Given this list of marker genes SIX2, TGFBR1, KPNA1, NPAT, TTC39B, ZNF124, ZNF514, CCNDBP1, IPMK, LIN28B, CRIM1, BCLAF1, PSG5, APOO, HYCC2, ZIC2, GIGYF1, TESMIN, AIRIM, DDX3Y, TMEM131, LMO1, LIN28A, GUCY1A2, TBPL1, ZNF426, LOX, GOLGA8A, PHACTR4, RIMKLB, GLCCI1, CD69, TREML4, RIOX2, UBE2D3, SMAP1, SS18L1, PRLR, CPEB4, DUSP6, ACVR2A, ADAMTS18, TNFSF4, KANK1, ZNF704, CTDSPL, EXD1, SLC2A3, OOSP2, OTOGL, PEAK1, DYNC1LI2, PI4K2B, DEK, PAK5, TCFL5, APBA1, PARP11, CDC40, STARD4, LGALSL, AGO4, PAX5, ZBTB43, NWD2, FBXO34 (F-box protein 34), PHC3, CPD, HEY2, ZDHHC17, PCDHA9, NAAA, GOLGA8N, FNDC3A, ZNF37A, SAMHD1, RFTN2, MYCBP2, ATP2B2, PPP5D1P (PPP5 tetratricopeptide repeat domain containing 1, pseudogene), CAMTA2, LMBRD2, CDON, KCNQ5, CARM1, GSKIP, CLUH, ZNF440, RPS6KB1, CEP83, RBM47, SPRY4, ZNF479, ITGA3, ZNF268, FBXO33, KLHL2, SYNPR, SCHIP1, CAMSAP2, CDC5L, GTSE1, TOGARAM1, AKIRIN2, TRDMT1, YOD1, PLCL2, ARHGEF7, CCNK, TNIK, ETFBKMT, GOLGA1, ACSL4, ZNF584, ANO1, MAP3K3, NR2C2, ARMH4, TIMP3, IL1A, TMF1, SYT16 (synaptotagmin 16), POC1B-GALNT4, SENP2, XPO7, SELENOT, AVL9, SORD, ENDOD1, NR4A3, GALNT4, MAN2A1, LRBA, ADARB1, FUT9, ZBTB4, TNFAIP1, YTHDC2 (NCBI Gene Id 64848), NUCKS1, MAB21L3, NPEPPS, PCDHA1, AASDHPPT, OTUD4, ENTPD6, CNOT2, BACH2, PITPNB, CDYL (chromodomain Y like), ADGRB3, PSG11, P3R3URF-PIK3R3, PAX9, MIDEAS, KIF3B, CNKSR2 (connector enhancer of kinase suppressor of Ras 2), BRWD1, SEC24C, PCDHA3, GLS, PSG3, FAM135A, LPCAT2, PHLDA1, PRTG, ZNF266, GPSM1, BRAP, DCBLD2, PRKCD, CNTN4, DEPTOR, ZDHHC3, RNF34, TRAK1, GOLGA6L9, ZNF780B, NEK7, DCAF12L1, AGFG1, RAB3IP, ZNF140, UBP1, CPOX, SPP1, ZNF544, SLC4A8, MUC22, PROSER1 (NCBI Gene Id 80209), ZNF655, C2CD5, CDKN3, DARS1, TRIM2, CEP97, TMEM123, ZNF563, QSER1, BEND3, HSP90B1, UBE3C, CNKSR3, SLC22A15, MED26, NAALADL2, FHAD1, SETX, GOT2, ZFP82, DNAJC3, ECT2L, ITGB8, IGDCC3, SIN3B, CHIC1, TBC1D14, RECK, RAB30, KATNBL1, AP1AR, PURB, PHF3, NUS1, LATS1, MEGF9, MBNL2, MAP7D2, GFPT1, FHIP1A, MTF2, ZNF844, FHIP1B, KDM5A, MB21D2, G3BP2, LAMA1, ETS1 (NCBI Gene Id 2113), ACVR2B, GRB10, GHITM (NCBI Gene Id 27069), ZNF302, CD302, NIPBL, ZFP36L2, EPC2, DCLK1, GPD1L, HOXA11, TMLHE, ZFAND4, PTGR3, NLK, MYO1E, SLC16A7, IGF2BP2, IKZF5, SEC24A, KCNH1, RASSF1, FOXP1, PIK3R3, ADO, PCSK1, PALM2AKAP2, CNTNAP3B, ATP2B3, TAFA2, HIC2, NOVA1, FSBP, TMEM87B, CDH8, RALA, ZNF814, TBC1D1, FAM3C, ZEB2, DCN, WDR82, CALCR, KRBOX4, OSBPL3, KLHL42, LCTL, ZNF699, ZNF800, ANKRD13C, RAB3C, SLITRK1, UNC80, FKBP1A (FKBP prolyl isomerase 1A), CAPS2, BLOC1S6, ZNRF2, CARF, BCL2L11, CBX7, CBLL1, NEXMIF, CECR2, GOLGA8R, YTHDF3, PLAU, ZNF83, PUM1, RASSF8, XRN1, PCDHA8, EPB41L3, SH3TC2, RAD54B, ZNF773, KCNA1, SCD, PCDHA12, CHD1, ZNF217, CA8, PCDHA10, CALM1 (NCBI Gene Id 801), TCF7L2, NOTCH2, GOLGA8J, ETV6, PER3, USP33, CXCL9, IL25, SESN3, C14orf28, FGD4, BMP2K, ASTN1, L1CAM, ZNF571, HIPK1, DNAJC13, ZSCAN23, CCL8 (NCBI Gene Id 96488), MINK1, NRXN1, TPRX1, UNC5D, AKIRIN1, ASPH, GRM5, TSC22D2, CLVS1, CBFA2T3, GATA6, CDS1, EPHA5, STXBP5, KMT2C, PPIP5K2, CHMP1B, TNF, TM9SF4, ABHD18, OR51E2, ADCY1, ADAM11, HOXD1, CUL3, CFAP161, PTPN22, NAB1, KAT2B, PCDHA4, ESR1, NAP1L1, MS4A1, PDE3A, SPECC1L, TOM1L1, RAD21, ZDHHC7 (NCBI Gene Id 55625), ST6GALNAC5, DDX3X, RALGAPB, PDCD4, DMXL2, ZNF597, BAZ2B, PSG9, AKAP6, PAFAH1B2, PDAP1, UBE2B, S1PR1, ZNF468, SLC5A9, SLAIN2, ZNF780A, C8orf44-SGK3, PPP1R12B, OXGR1, EXOC5, HMBS, KIAA1217, GATM, BIRC6, GCC2, ZNF823, MAPK1IP1L, ZNF586, KLHL5, SRPK2, ARFGEF3, TGFBRAP1, ESM1, IRS2, ASAH2B, LEMD3, KLHL29 (NCBI Gene Id 80137), DCUN1D1, GSE1, RNF217, PCDHAC1, MUC7, CHL1, PTPDC1 (protein tyrosine phosphatase domain containing 1, NCBI Gene Id 138639), MAP1B, MFSD6 (major facilitator superfamily domain containing 6), LYRM1, SEPTIN8, GPBP1, ZNF439, THRB, LNPK, ZNF700, TCERG1, TBC1D4, PCDHA6, ZNF568, TMEM144, BRD1, QKI, ATXN1, WNK1, NAA50, E2F5, ZIC3, PCNP, PPFIA1, ZFP90, PCDHA5, ATMIN, BTBD3, HECA, ATP2A2, BCL2, EN1, OTUD1, ATP8B2, PNRC2 (NCBI Gene Id 55629), ZNF527, CREBRF, ZNF781, PTBP3 (polypyrimidine tract binding protein 3), JARID2, C2orf69, KPNB1, CERS3, PAWR, WSB1, ACAP2, POU2F1, UBE2D1, PCDHAC2, PUDP, GOLGA8Q, TMEM94, MTX3, PTBP2, RLIM, TMEM165, HOXC8, C16orf87, ZNF14, MARCHF6, ARMC8, HEATR3, BAG4, METAP1, SSX2IP, SRSF7, LCLAT1, TRDN, COX15, PLEKHJ1, NEGR1, ZFAND6, ACAD8, CAMK2D, GPR83, MARK1, AK9 (adenylate kinase 9), LRRN1, E2F7, FSD1L, JADE2, FNIP2, GOLGA8T, ZBTB41, EPHA4, LIG4, CUL5, SPIRE1, HIPK3, SIK3, RAI1 (retinoic acid induced 1), ENAH, ADAMTSL1, MAMDC2, MORC3, EYA3, AP1S3, SLC10A7, VPS41, PBX3, LRRC32, LRRC8D, ACER3, POLQ, CBLB, CDKN2AIP, ATL1, BOLL, LPCAT1, USP15, HOXA1, IPO7, ONECUT2, ITPRID2, ATXN3, MGAT2, SLC25A37, KIAA1549L (NCBI Gene Id 25758), PCDHA7, OGFRL1, GOLGA8M, SOWAHA, PLEKHA3, TNFRSF11B, ARF6, GOLGA6L4, GRIA3, PCDHA2, TAOK1, ZNF559, JAZF1, MTURN, SIX4, CAPRIN1, MCC, PPP2R5E, FIGN, PALS1, MSANTD3-TMEFF1, RNMT (NCBI Gene Id 8731), ATXN7, RAB3GAP1, NIPAL4, RASSF2, RAB8B, PTPN4, SIPA1L2, PRKAG2, TXNDC12, TADA1, ANKRD44, OSBPL2, SPTY2D1, IPO8, N4BP2, POLI, FNDC3B, OSBPL8, TMEM64, TFRC, AHCTF1, SLC7A11, PDGFRA, ZNF329, CBX4, NOTCH4, HAO1, PPP2R3A, HCN2, TNPO1 (NCBI Gene Id 3842), CHMP2B, TET2, ZNF136, PRRC2C, IQCJ-SCHIP1, SLC7A1, SPTLC1 (serine palmitoyltransferase long chain base subunit 1), ARL5A, SACM1L, ADCY9, PKNOX2, TRIM71, LARP4, MBTPS2, CCNJ, METAP2, DDIT4, LIF, KRAS, CD4, PRDM4, SH2B3, ZNF189, RNF169, KIF1B, RAP1B, CREB1, ZFP14, ETNK1, ADRA1A, EYS, PIAS1, CTTNBP2NL, GOLGA8H, LIMCH1, PDE5A, KLF6, USP42, DSE, GOLGA8B, NMBR, SSB, CCP110, UBL3, ATP1B1, LY75-CD302, REPS2, HRH1, RBBP7, TENT4B, PPARA, SLC4A10, MICU3, MTMR12, CNTNAP2, CPSF6, YLPM1, PSPC1, BHLHE40, NKAIN2, MBOAT2 (NCBI Gene Id 129642), PPP3R1, PCDHA13, ARSJ (NCBI Gene Id 79642), PAPOLG, PRR27, SRGAP2, KIF3A, SLC38A11, EPB41, TGFBR2, SPRING1, MTPN, ARNT2, DERL1, DYNC2H1, RBM46, KHDC1, PHIP, ZNF44 (NCBI Gene Id 7610), B4GALT1, FRYL, DISC1, TAB3, HYOU1, CDK17, ARHGEF3, TMEFF1, ZFP62 (NCBI Gene Id 92379), PHF20L1, GRIK2, ASPN (NCBI Gene Id 54829), TNRC6B, TBL1X, COPS2 (NCBI Gene Id 9318), SLC12A5, TBCEL, IL2, GAPVD1, ZNF283, SALL4, PLAG1, PABIR2 (NCBI Gene Id 159090), NR6A1, DOCK4, KLF15 (KLF transcription factor 15), NFAT5, AP1G1, GPRIN3, ATP2B1, RLF (NCBI Gene Id 6018), GPR137C, PPP1R3B, ANKEF1, SLC35E1, NR1D2 (NCBI Gene Id 9975), SLC25A36, GABRA1, ZFP1, PCDHA11, CAPRIN2, KCNJ10, SERTAD2, TNS1, PROX1, ST8SIA4, RNF6, KMT2A, MYBL1, SGK3 (NCBI Gene Id 23678), FRMD8, PLA2G4A, AFG3L2, CLASP1, MIER3, ZFP36L1, ZBTB2, CDC73 (NCBI Gene Id 79577), DLG2, AKT3, SEMA4G, GPD2, RNF182, ATP11C, TAB2, NLN, TADA2B, NSUN7, WASL, ZNF594, PHTF2, MEX3B, ATM, NELFA, PNMA2, RPS6KA3, ADAMTS6, ABTB2, CPNE2, AMER2, VANGL1, TLL1, ZNF121, MLXIP, NCALD, PAM, SLC35F3, RFC1, RORA, NCOA2, CHCHD7, INO80D, PNISR, DCLK3, CLIP1 (NCBI Gene Id 6249), TMED4, DNAJA4, PARM1, ADAMTS5, here is a description of the gene set: Genes predicted to be targets of miRBase v22 microRNA hsa-miR-4262 in miRDB v6.0 with MirTarget v4 prediction scores > 80 (high confidence targets). Human Gene Set: MIR4262 from publication Chen Y, Wang X (PMID 31504780) studied in species Homo sapiens